The following is a description of a gene set: The expansion of a B cell population by cell division. Follows B cell activation. Human Gene Set: GOBP_B_CELL_PROLIFERATION studied in species Homo sapiens, and this is the list of marker genes: CD300A, IL13, NFKBIZ, TNFSF13, MNDA, CD74, TFRC, SASH3, TIRAP, TICAM1, PRKCD, CDKN2A, TCF3, GPR183, BMI1, IGHE, CASP3, MEF2C, CD38, PLCL2, CLCF1, VAV3, CARD11, IL2, FCRL3, MS4A1, NFATC2, PTPRC, FOSL2, PKN1, MZB1, BTK, RAG2, TYROBP, WNT3A, IKZF3, CD180, IL7R (interleukin 7 receptor), TNFRSF13C, ATAD5, BCL2, CDKN1A, SHB (SH2 domain containing adaptor protein B), ATM, HSPD1, TLR9, IL7, TNFSF13B, BAX (BCL2 associated X, apoptosis regulator), MIF, CD79A, CHRNB2, IFNB1, TNFRSF4, ADA, TNFRSF21, FCGR2B, IRS2, CD19, BCL6 (BCL6 transcription repressor), ABL1, LYN, CD40, IL4 (NCBI Gene Id 3565), RASGRP1, BST1, AHR, CD40LG, CD70, GAPT, LEF1 (NCBI Gene Id 51176), PRLR, CTPS1, IL5, EPHB2, PELI1, SLC39A10, TLR4, IL10, PAWR, PCYT1A, MIR185, INPP5D, RC3H1, CD22, TNFRSF13B, IL21, CD81, CD320, IL9, CTLA4, CR2, NCKAP1L (NCBI Gene Id 3071)